The following is a description of a gene set: Human Gene Set: GSE9006_HEALTHY_VS_TYPE_1_DIABETES_PBMC_4MONTH_POST_DX_UP studied in species Homo sapiens Genes up-regulated in comparison of peripheral blood mononuclear cells (PBMC) from healthy donors versus PBMCs from patients with type 1 diabetes at 4 month after the diagnosis. Objective: We hypothesized that type 1 diabetes (T1D) is accompanied by changes in gene expression in peripheral blood mononuclear cells (PBMCs) due to dysregulation of adaptive and innate immunity, counterregulatory responses to immune dysregulation, insulin deficiency and hyperglycemia. Research Design and Methods: Microarray analysis was performed on PBMCs from 43 patients with newly diagnosed T1D, 12 patients with newly diagnosed type 2 diabetes (T2D) and 24 healthy controls. One and four month follow-up samples were obtained from 20 of the T1D patients. Results: Microarray analysis identified genes differing in expression between newlydiagnosed T1D patients and controls at a false discovery rate of 0.05. Changes in expression of interleukin-1β (IL1B), early growth response gene 3 (EGR3), and prostaglandin-endoperoxide synthase 2 (PTGS2) resolved within four months of insulin therapy and were also observed in T2D suggesting that they resulted from hyperglycemia. With use of a knowledge base, 81/genes could be placed within a network of interrelated genes with predicted functions including apoptosis and cell proliferation. IL1B and the MYC oncogene were the most highly-connected genes in the network. IL1B was highly overexpressed in both T1D and T2D, whereas MYC was dysregulated only in T1D. Conclusion: T1D and T2D likely share a final common pathway for beta cell dysfunction that includes secretion of interleukin-1β and prostaglandins by immune effector cells, exacerbating existing beta cell dysfunction, and causing further hyperglycemia. The results identify several targets for disease-modifying therapy of diabetes and potential biomarkers for monitoring treatment efficacy. from publication Kaizer EC, Glaser CL, Chaussabel D, Banchereau J, Pascual V, White PC (PMID 17595242), and this is the list of marker genes: MSN, PLIN3, PDCD1LG2, TPD52L2, MFSD1, PTEN, UAP1, ANXA5, DOCK2, YPEL5, PIGA, RTN3, GLUD2, BTBD1, ACTR2, PPP2R5E, TERF2IP, ECPAS, SRSF9, IRF1, TUBA3D, HMGB1, SAFB, ECSIT, HNRNPA3, CIRBP, UBAC1, CHFR (NCBI Gene Id 56732), PABPC4, FEM1B, PIGT, KLF9, CD69, RAB5B, SUMO3, TYMP (NCBI Gene Id 4334), DUSP10, NAPG, SAFB2, FAM53C, CREM, KLF11, ILKAP, NFKB2, RNF19B, YWHAZ, EPS15, ADAM9, HNRNPD, PDIA4 (protein disulfide isomerase family A member 4), SLC2A3, HADHA, ODF2, HNRNPH2 (NCBI Gene Id 3188), SNF8, EIF4H, GBA1LP, LAPTM5, DNAJA2, PABPC1, NFKBIE, ARHGAP26, CPNE3, KIAA0930, MBD2, MKRN1, MAPRE1, SEC31A, XRCC6, ZNF394, ILVBL, PSMD2, ASMTL, CARF, PTGES3, NFKBIA, USP7, ATMIN, ASCL2, STRAP, CPSF6, RRAGD, G3BP2, MVP, VDAC1, COPA, TAP2, LYPLA1, COPS7B, G0S2, ATF4, DAZAP2, ALDOA, NR4A2, SFN, SIK1, PKN1, HNRNPU, TOM1, ZNF551, SFPQ, NADSYN1, PAK2, HNRNPA1, DDIT4, RNF11, TMED2, CLP1, AGPS, DPYSL2, KLF10, NKAPD1, DDX3X, WTAP, RNF38, MAPK1IP1L, NRIP1 (NCBI Gene Id 8204), PDIA3, ATP1B3, RETREG2, SF3A1, CKAP4, GNAI3, CYBB, FLI1, OSTF1, TOR3A, HIF1A, RIOK3, NUP93, TSR3, NPTN, HSPA9, TNFAIP3, LAP3, UQCRC1, BNIP2, TESK2, PPFIA1, YBX3, AATF, JUNB, QKI, SUCLG2, STK17B, TOB1, GPI, RPN1, PCBP2, CXCL5, SNX6, GADD45B (NCBI Gene Id 4616), MTMR12, PIK3R1, TPST2, HNRNPM, GLUL, ACTG1, ATF3, DUT, RAP2C, COTL1, EIF4G3, SCPEP1, KPNB1, AZIN1, DDX21, SIL1, GLUD1, CTSB, OLA1, LSM12, DUSP5, PRMT7, NDUFV1, SRRM1, SCO2, MAFF, PTP4A1, ADNP2, RBM3, SART1, HAUS3, TSC22D3, RNASEH1, SEC63, TWF1, PPP1CB, C8orf33, CXCR4, TAOK3, SPCS3, BHLHE40, IER5, REEP4, JUN, AKIRIN1, MARCKS, AAMP, AHCY